Given this list of marker genes BAK1, ASS1, LCN2, ABCB1, CERS1, here is a description of the gene set: studied in species Homo sapiens Human Gene Set: GOBP_RESPONSE_TO_MYCOTOXIN Any process that results in a change in state or activity of a cell or an organism (in terms of movement, secretion, enzyme production, gene expression, etc.) as a result of a mycotoxin stimulus. A mycotoxin is a toxic chemical substance produced by fungi.